The following is a description of a gene set: species: Homo sapiens Neighborhood of NF1 neurofibromin 1 (neurofibromatosis, von Recklinghausen disease, Watson disease) in the MORF expression compendium Human Gene Set: MORF_NF1 Neighborhood of NF1, and this is the list of marker genes: BCL2, WBP4, TBC1D22A, MSX1, EPHB2, GRIP2, BMP10, SLC6A11, SLC6A7, MT4, GNPAT, JRK, GPLD1, SYT5 (NCBI Gene Id 6861), BRCA1, PLEKHB1, EXTL3, ERC1, SKI, CASP10 (caspase 10), MFN1, KRT33B, PAX9, PSG1, DAPK2, TRIM24, NFX1, CELA2B, CFH, NR1I2, EN2, FIG4, NXPE3, ABCC8, NF1, ZP2, SP140, AFF2, CCKAR, KRT2 (NCBI Gene Id 3849), TBX5, SULT2B1, GJB5, HOXD4, ZNF500, NRP2, MC5R, ABO, CEACAM4, PRELID3A, RREB1, SLC4A3, SIM2, WT1, NTNG2, CYP2E1, ETV3, GPR3, GSTM5, GRIK5, ITPR2, LTBP4, SLC30A3, FOSL1, SMYD5, POLR2K, SCAPER, MSL3, ZNF266, LPGAT1, DRC3, ZBTB22, KRR1, KRT33A, PIGR, CAMK2G, FRY, MLN, LEFTY1, ABCB10, DNAJC16, ATP6V1B1, MYO9B, TFDP2, ADCYAP1, FNTB, ARL3, NEUROD2, MSH3, FRYL, BRD1, NFAT5, IGKV7-3, COLGALT2, OPLAH, SLC22A6, SLC25A11, IRS2 (NCBI Gene Id 90066), SLC18A1, IFT27, FUT6, IL13, COX6A2, POFUT2, TMEM11, TNFRSF25, PIK3CB, PVR, SULT4A1, AGPS, CTRL, ABCB9, IRF2, DTX4, KLHL18, NOS2, ESR1, HOXD13, TSSK2, RPS6KA5, IL16, IL11RA, CYP2D6, DPT, RXRG, ATP6V0A2, OPRL1, ERCC4, ENTREP1, AQP7 (aquaporin 7), ZNF133, HTR4, ELAVL2, LBP, STK17A, DTNA (NCBI Gene Id 86552), SLC13A2, FLT1, GLE1, SLC2A1, DKK4, TMPRSS6, AQP5, KRT86, MAGEA9, GPATCH8, ITIH4, KANK3, PRKACA, GTSE1, NRTN, POU6F2, PAXIP1 (NCBI Gene Id 22976), AOC4P, LY9, ADCY3, CYP11A1, ZNF592, HTR7, POU6F1, DOCK1, RASSF1, TBX19, SPEF1, SLC16A5, FGF18, PIGB, CYP2A6, P2RY10, PDE4D